Given this list of marker genes C1orf127, CFAP52, CFAP45 (NCBI Gene Id 25790), CCDC39, ENKUR, PIERCE1, DNAAF2, CIROP, here is a description of the gene set: Human Gene Set: GOBP_ESTABLISHMENT_OF_LEFT_RIGHT_ASYMMETRY The initial formation of the type asymmetry in an organism's body plan or part of an organism with respect to the left and right halves. studied in species Homo sapiens